The following is a description of a gene set: studied in species Mus musculus The modification of peptidyl-arginine. Mouse Gene Set: GOBP_PEPTIDYL_ARGININE_MODIFICATION, and this is the list of marker genes: Prmt1, Prmt7, Ndufaf5, Prmt5, Prdm1, Prmt8, Park7, Ndufaf7